The following is a description of a gene set: Reactome Pathway: Metabolism of RNA species: Mus musculus electronically inferred by orthology from the curated human pathway This event has been computationally inferred from an event that has been demonstrated in another species.<p>The inference is based on the homology mapping from PANTHER. Briefly, reactions for which all involved PhysicalEntities (in input, output and catalyst) have a mapped orthologue/paralogue (for complexes at least 75% of components must have a mapping) are inferred to the other species., and this is the list of marker genes: Srsf3, Ptbp1, U2af2, Gtf2f1, Xrn2, Nup85, Fcf1, Snrpa, Rpl18, Mfap1b, Emg1, Rpl4, Smn1, Csnk1e, Senp3, Eif4a1, Psmd12, Utp11, Polr2f, Rps17, Nop56, Psmb5, Eif4a2, Cpsf1, Zfc3h1, Rps12, Ccnh, Slbp, Rngtt, Rpl37rt, Cactin, Rps20, Gnl3, Psmb7, Psmc5, Psmd6, Lsm11, Snrpa1, Zfp36, Zcrb1, Patl1, Rpl12, Rbm27, Gemin2, Upf3b, Lsm8, Lsm1, Zc3h18, Qng1, Thoc3, Dhx15, Gemin5, Lsm4, Nup58, Sarnp, Nup42, Rps9, Wdr43, Snrnp40, Rnps1, Rps18, Eri1 (NCBI Gene Id 67276), Rpl3l, Cnot7, BC005624, Psmc4, Rpl11, Snrpf, Ddx52, Ndc1, Cdc5l, Pes1, Rpp25, Thoc6, Leng1, Nup133, Xab2, Zfp473, Snip1, Pabpc1, Fau, Ddx21, Rpl13, Prpf3, Las1l, Tnks1bp1, Rpp14, Polr2k, Psma2, Hnrnpk, Ercc2, Rbmx, Prkca, Rnf113a1, Steep1, Bud23, Psmd7, Psma6, Rpl3, Rpl24, Srsf8, Psma5, Usp39, Snu13, Rpl18a, Rps2, Nkap, Zcchc8, Smg8, Ddx23 (DEAD box helicase 23), Wdr82, Papolg, Rpl7, Rps4x, Rpl26, Rpl36al, Sde2, Psmc3, Rpl9, Ppil2, Ppp1ca, Nup205, Rpl36a (NCBI Gene Id 19982), Ppp2r2a, Polr2a, Utp4, Rps13, Rps3a1, Nsrp1, Nob1, Srrt, Ppig, Snrpg (small nuclear ribonucleoprotein polypeptide G), Polr2e, Magohb, Snrnp25, Rpl23a, Rps26, Tnfsf13, Xpo1, Dcp2, Rrp7a, Ddx20, Rrp9, Yrdc, Rpl27, Bud13, Ctnnbl1, Smndc1, Ppil1, Smg7, Snrnp35, U2surp, Prmt5, Aaas, Nup54, Hnrnph1, Dhx35, Snupn, Rps10, Lsm2, Syf2, Prpf19, Rplp2 (ribosomal protein lateral stalk subunit P2), Cpsf3, Snrpn, Nop58, Tut1, Rpl19, Dcaf13, Psmc6, Ercc3, Riok3, Magoh, Pcbp1 (NCBI Gene Id 23983), Sugp1 (SURP and G patch domain containing 1), Cwc27, Edc4, Nup155, Rps27l, Rps25, Supt5 (suppressor of Ty 5, DSIF elongation factor subunit), Mfap1a, Ubb, Pcbp2, Rrp36, Eftud2, Psmd13, Dcp1a, Prcc, Edc3, Polr2c, Ddx41, Fbl, Prkrip1 (Prkr interacting protein 1 (IL11 inducible)), Pno1, Rps7 (NCBI Gene Id 20115), Ik, Phf5a (PHD finger protein 5A), Gtf2h2, Polr2l, Polr2i, Zfp830, Nol11, Psma4, Rbm17, Alyref, Rpl38, Rpl6, Mtrex, Snrnp27, Psmd1, Rps15, Rps6, Sart1, Prpf18, Psma1, Rpl14, Psma7, Rps5, Rnf113a2, Hnrnpr, Snrpc, Nup93, Rbm22, Srsf5, Nxf2, Srsf10, Seh1l, Rps11, Sf3b5, Rpp21, Rpl15, Psma3, Pelp1, Dhx16, Psmc1, Rpl39l (ribosomal protein L39-like), Nup210, Rps23, Luc7l3, Cnot4, Nxf7, Srrm2, Gtf2f2, Polr2b, Prr3, Tfip11, Gtf2h4, Apobec4 (NCBI Gene Id 71281), Apobec3, Zc3h4, Rps19, Thoc7, Hnrnpf, Zmat5, Rps27a, U2af1l4, Wbp4, Ltv1, Rae1, Cdc40 (cell division cycle 40), Psmb6 (NCBI Gene Id 19175), Dhx8, Papola, Mettl14, Lsm6, Clp1, Sf3a3, Utp6, Rpl37a, Gspt2, Gemin7, Rps28, Rpl29, Rnmt, Rps8, Casc3, Rpl39, Prpf4, Rpl37, Psmc2, Ddx39a, Rpl27a, Rbm5, Hnrnph2, Yju2, Hspb1, Snw1, Fam32a, Apobec2 (NCBI Gene Id 11811), Nop14, Cnot10, Psmb4, Wdr33, Upf2, Gpatch1, Ubl5, Fip1l1, Rps24, Exosc10